The following is a description of a gene set: Mammalian Orc1 protein is phosphorylated and selectively released from chromatin and ubiquitinated during the S-to-M transition in the cell division cycle. Reactome Pathway: Orc1 removal from chromatin part of: Switching of origins to a post-replicative state studied in species Homo sapiens, and this is the list of marker genes: PSMC6, PSMB3, PSMD6, ADRM1, PSMD3, PSMA6, PSMA5, MCM3, PSMD14, PSMA2, PSMB4, MCM2, UBA52, PSMD8, PSMB5, ORC3, PSMD12, ORC5, PSMB2, CCNA1, PSMB7, SKP2, PSMC2, CUL1, MCM5 (NCBI Gene Id 4174), ORC2, PSMD11, PSMD2, ORC1, ORC6, UBB (ubiquitin B), SKP1, SEM1 (NCBI Gene Id 7979), PSMC3, PSMA1, CDT1, MCM4, PSMA7, MCM8, PSMD13, UBC, PSMC5, MCM6 (NCBI Gene Id 4175), PSMC1, RBX1, PSMB1, CDK2, PSMD7, CDC6, PSMC4, PSMD1, ORC4, PSMA4, PSMB6, MCM7, RPS27A, PSMA3, CCNA2